The following is a description of a gene set: Comprehensive identification of all functional elements encoded in the human genome is a fundamental need in biomedical research. Here, we present a comparative analysis of the human, mouse, rat and dog genomes to create a systematic catalogue of common regulatory motifs in promoters and 3' untranslated regions (3' UTRs). The promoter analysis yields 174 candidate motifs, including most previously known transcription-factor binding sites and 105 new motifs. The 3'-UTR analysis yields 106 motifs likely to be involved in post-transcriptional regulation. Nearly one-half are associated with microRNAs (miRNAs), leading to the discovery of many new miRNA genes and their likely target genes. Our results suggest that previous estimates of the number of human miRNA genes were low, and that miRNAs regulate at least 20% of human genes. The overall results provide a systematic view of gene regulation in the human, which will be refined as additional mammalian genomes become available. from publication Xie X, Lu J, Kulbokas EJ, Golub TR, Mootha V, Lindblad-Toh K, Lander ES, Kellis M (PMID 15735639) Genes having at least one occurrence of the highly conserved motif M90 YAATNRNNNYNATT in the regions spanning 4 kb centered on their transcription starting sites. The motif does not match any known transcription factor binding site. Human Gene Set: YAATNRNNNYNATT_UNKNOWN studied in species Homo sapiens, and this is the list of marker genes: DLL4, CCSER2, SHOX2, SMAP2, ELF5, FOXN3, COL9A2, MPPED2, BMPR1B, TAF10 (TATA-box binding protein associated factor 10), ELAVL2, CHRND, ACVR2A, DDX17, PHF8, TGIF1, NOTCH2NLA (NCBI Gene Id 388677), TMEM178A, PTF1A, KCNJ16, IFNK, MAGI1, CLRN1, RPA3, HIVEP1, POLG2, NFIX, IGSF21, CDH13, ABLIM1, EDC4, TRPM1, ABHD17B, ACACA, LHX6, HOXA7, ELAVL4, RCN1, ZNF423, EYA1, CNTNAP4, MTUS1, BHLHE41, LMO3, CREB5, ZNF485, CREM, ADCYAP1, SLC26A9, NOL4L, ASCL4, ASXL1, DCT, SULF1, MYH4, HOXB8, PDHX, NOTCH2, MIR137HG, TNMD, BDNF, ROBO3, OTP, RTRAF, HEPACAM, SOX14, OGDHL, SSPN, ERF (NCBI Gene Id 2077), RBMS1, ERG, NPVF, DCX, WSB2, COMMD10, PNOC, PHOX2B, PCGF1, CACNA1C, LRP5, HOXB3, CELF2, MYO15A, SERPINF1, IPO4, SIAH3, BARHL1 (BarH like homeobox 1), HAS2 (hyaluronan synthase 2), PACSIN3 (protein kinase C and casein kinase substrate in neurons 3), BNC2, IKZF5, CORO2A, MN1, ACADSB (NCBI Gene Id 654185), SLC24A4, EPHA7, SESN3, COX8A, NPAS3, ZDHHC21, ELF4, IRX4, NOB1, ZFP36L1